Given this list of marker genes Bace1, Cltc, Ap1b1, Dnm3, Prkch, Nsf, Gsk3b, Dnajb2, Dnm2, Fermt2, Mapk8, Naip5, Dnm1l, Naip6, Cdkn1a, Axin1, Naip1, Prkce, Xiap, Naip2, Ap2a2, Gsk3a, App, Akt1, Map3k7, Dnm1, Dazap2, here is a description of the gene set: Mouse Gene Set: GOMF_PROTEIN_SERINE_THREONINE_KINASE_BINDING species: Mus musculus Binding to a protein serine/threonine kinase.